The following is a description of a gene set: Human Gene Set: GOBP_REGULATION_OF_AXON_EXTENSION studied in species Homo sapiens Any process that modulates the rate, direction or extent of axon extension., and this is the list of marker genes: RTN4, POU4F2, GSK3B, SEMA5A, PLXNA4, CDK5, RNF6, MAP2, NRCAM, ANAPC2, CLASP2, ZFYVE27, RAB21, DIP2B, NKX6-1, NRP1, BMPR2, SMURF1 (NCBI Gene Id 730332), MAP1B, BARHL2, RYK, TNR, PLXNA3, WNT3, BCL11A, CXCL12, MEGF8, OLFM1 (NCBI Gene Id 22825), SEMA6D, CDKL5, SEMA3F, WNT3A, RTN4R, DISC1, SEMA3A (semaphorin 3A), TRPV2, SEMA7A, SEMA4F, ISLR2, SLIT1, SEMA3G (semaphorin 3G), ADCY10, DSCAM, ABL1, SIN3A, SRF, PTPRS, CTTN, GOLGA4, ARHGAP4, TTL, MAPT, MT3, CDH1, ADNP, TNFRSF12A, NGF, LIMK1, KIAA0319, L1CAM (NCBI Gene Id 4268), SHTN1, CDH4, IFRD1, MAP3K13, MACF1, PAK1, MAG, WNT5A, PAFAH1B1, DRAXIN, TRIM46, NTRK3, CDKL3, GDI1, APOE, RUFY3, NTN1, HDAC6, DNM2, TRPC5, FN1, VEGFA, TWF2, SEMA6C